The following is a description of a gene set: This event has been computationally inferred from an event that has been demonstrated in another species.<p>The inference is based on the homology mapping from PANTHER. Briefly, reactions for which all involved PhysicalEntities (in input, output and catalyst) have a mapped orthologue/paralogue (for complexes at least 75% of components must have a mapping) are inferred to the other species. studied in species Mus musculus electronically inferred by orthology from the curated human pathway part of: Sensory Perception Reactome Pathway: Olfactory Signaling Pathway, and this is the list of marker genes: Or56a5, Or8b56, Or1e19, Or5p80, Or2t47, Or1e21, Or1e16, Or11h4, Or14a260, Or2l13, Or11a4, Or7c70, Or11h6, Or6f1, Or1e34, Or2f1, Or1e23, Or7g27, Or1e30, Or3a1, Or8b3b, Or51ai2, Or1a1b (NCBI Gene Id 258706), Or8b3, Or2j3 (olfactory receptor family 2 subfamily J member 3), Or10g3, Or13c3, Or8d23, Or5k1, Or4c12, Or4l1, Or5d14, Or1e22, Or4d2b, Or6p1, Or2a51, Or2b11, Or11h4b, Or1e26, Or14j1, Or8k3, Or1e33, Or10x1, Or1e31, Or1e35, Or10g7, Or51e1, Or5k1b, Or1e1, Or2t46, Or5al1, Or2at4, Or10s1, Or1n2, Or51d1, Or1d2, Or10g9, Or2a20, Or4q3, Or2t48, Or10g9b (NCBI Gene Id 259110), Or9g20, Or1e32, Or8u9, Or1e29, Or1e1c